Given this list of marker genes SLC26A4, SLC26A9, SLC26A5, SLC26A3, SLC26A1, SLC26A6, AGXT, SLC26A8, SLC26A2, SLC26A7, SLC26A11 (NCBI Gene Id 65011), SLC26A10P, here is a description of the gene set: The directed movement of oxalate into, out of or within a cell, or between cells, by means of some agent such as a transporter or pore. Oxalate, or ethanedioic acid, occurs in many plants and is highly toxic to animals. Human Gene Set: GOBP_OXALATE_TRANSPORT species: Homo sapiens